Given this list of marker genes Cited2, Hycc1, Hnrnph2, Heyl, Rps6ka5, Ppp1r9a (protein phosphatase 1, regulatory subunit 9A), Atg2b, Ippk, Atp6v1g1, Crebzf, Tpd52, Hnrnpf, Lrrtm3, Tmed2, Arpc2, Olig2, Epc1, Cyct, Rtn3, Erlec1, Pcdh9, Prkd1, Slc35a3, Smad1, Dr1, Cnot6, Zfp37, Ercc3, Hoxa5, Fam117b, Col19a1, Fgd4, Lancl2, Dusp22, Ret, Agfg1, Tcf7l2, Pitx2, Ro60, Trim33, Zfp26, Nfya, Tmem11, Krtap13-21, Gfral, Slain2, Son, Dppa3, Ncam1, Thsd7a, Hs3st1, Akr1c19, Phkb, Ccdc80, Rora, A830018L16Rik, Nrbp1, Gpr174, Rnf6, Zswim6, Pnkd, Dnajc12, Nufip2, Sco1 (SCO1 cytochrome c oxidase assembly protein), Rbm26, Ssh2, Neo1, Pdzrn3, Scaf8, Supt4a, Atp2b1, Ttc8 (tetratricopeptide repeat domain 8), Zmynd15, Arhgef6, Asap2, Slmap, Myo5c, Zfp945, Slc66a2, Zfp608, Rapgef6, Rpn2, Fbn1, Nusap1, Srsf2 (serine and arginine-rich splicing factor 2), Arf1, Myocos, Yae1d1, Cth, Ddi2, Fam169a, Cst5, Pbrm1, Mbnl1 (NCBI Gene Id 56758), Chst2, Ica1l, Kifbp, Gpr17, Ankib1, 2210408I21Rik, Skil, Mtdh, here is a description of the gene set: Mouse Gene Set: MIR_7B_3P Genes predicted to be targets of miRBase v22 microRNA mmu_miR_7b_3p in miRDB v6.0 with MirTarget v4 prediction scores > 80 (high confidence targets). studied in species Mus musculus from publication Chen Y, Wang X (PMID 31504780)